The following is a description of a gene set: Human Gene Set: GOBP_AROMATIC_AMINO_ACID_METABOLIC_PROCESS The chemical reactions and pathways involving aromatic amino acid family, amino acids with aromatic ring (phenylalanine, tyrosine, tryptophan). studied in species Homo sapiens, and this is the list of marker genes: HPDL, TPH2, DCT, TAT, GSTZ1, GCDH, IYD, THAP4, TDO2, PAH, KYNU, HDC, IDO1, ATP7A, HGD, TPH1, TYR, UROC1, TTC36, AMDHD1, FAH, CARNMT1, HAL, HPD, IDO2, IL4I1, PARK7, AFMID (arylformamidase), SLC45A2, TH, OCA2, QDPR, KMO, FTCD, PCBD1 (pterin-4 alpha-carbinolamine dehydratase 1), HNMT, HAAO, ACMSD, CARNS1 (NCBI Gene Id 57571), NADSYN1 (NCBI Gene Id 55191)